Given this list of marker genes Art3, Parp1, Parp16, Art2a, Parp2, Art4, Tiparp, Art5, Parp10, Parp9, Parp12, Tnks, Parp4, Parp3, Art2b, Sirt6, Tnks2, Art1, Arl6, Parp14, Parp6, Arf4, Parp8, Parp11, Zc3hav1, Sirt4, here is a description of the gene set: Catalysis of the reaction: amino acyl- + NAD+ = H+ + (ADP-D-ribosyl)-amino acyl- + nicotinamide. Mouse Gene Set: GOMF_NADPLUS_PROTEIN_MONO_ADP_RIBOSYLTRANSFERASE_ACTIVITY studied in species Mus musculus